Given this list of marker genes TRAF2, TNFRSF11A, TNFSF12, LTA, LTB, CD40, TNFRSF13C, TNFSF13B, CD40LG, TRAF3, TNFRSF12A, BIRC3, LTBR, BIRC2, TNFSF11 (TNF superfamily member 11), MAP3K14, TNFSF14, here is a description of the gene set: Human Gene Set: REACTOME_TNF_RECEPTOR_SUPERFAMILY_TNFSF_MEMBERS_MEDIATING_NON_CANONICAL_NF_KB_PATHWAY TNF receptor superfamily (TNFSF) members mediating non-canonical NF-kB pathway species: Homo sapiens